Given this list of marker genes P2RY6, ITPK1, ITPKB, PTAFR, PLCG2, P2RY1, SCP2, GPER1, LHCGR, PLCB1, IPMK, here is a description of the gene set: Human Gene Set: GOBP_INOSITOL_TRISPHOSPHATE_METABOLIC_PROCESS studied in species Homo sapiens The chemical reactions and pathways involving myo-inositol phosphate, 1,2,3,4,5,6-cyclohexanehexol, with three phosphate groups attached.